The following is a description of a gene set: Human Gene Set: HP_ABNORMAL_HEART_MORPHOLOGY Any structural anomaly of the heart. studied in species Homo sapiens Abnormal heart morphology, and this is the list of marker genes: KAT6B, PORCN, SLC6A6, KIF7, AMMECR1, VPS13B, FBN2, BBS7, MYOT, SLC32A1, PEX14, FRAS1, COL1A1, SEC63, ALG1, SLC22A5, RAB34, FRA10AC1, STAT2, LAMA3, BUB1, CEP19, GALE, NEK10, NFS1, GPC3 (glypican 3), FAM149B1, CEP295, TGIF1, MCM10, TRIP4, CDC42, SMG9, SIN3A, PKD2, ODAD3, GATA6, EBP, NEUROD2, ITK, NUP155, EFEMP2, GATA3, SLC31A1, CXCR4, MNS1, CALCRL, FKRP, HGD, ERCC3, MT-TS2, PRDM13, TTC7A, MT-TW, RAD51C, CPT1A, QRSL1, SRCAP, HAND2, NDUFB10, LAMA2, GNB5, EFL1, FANCD2, IL17RA, TAF2, PLCH1, TMEM67, MYH11, SLC19A2, CEP290, WASHC5, TASP1, MBTPS2, CAV1, VHL, BBS12, BCS1L, MEOX1, ERCC6, TALDO1, GNB2, ACTN2, YARS1, EPCAM, CISD2, BRAF, PPCS, DNAH1, LAMB2, MAX, MYOZ2, PRKG1, FASTKD2 (NCBI Gene Id 22868), ALG8, PSMB9, SOS1, MFAP5, BUB3, KMT2A, RNF113A, SLC34A2, FOXE3, CLPB, GPX4, RPS26, AXIN1, MIB1, IQSEC2, TRAF7, CAPN15, SGCA (NCBI Gene Id 6442), ERAP1, CCDC32 (NCBI Gene Id 90416), AGK, NAGA, GLI2, SETD5, ACVR2B, UBE3B, PIGL, PPM1D, ACSL4, MT-ND6, PGAP1, TMEM218, ADAMTS19, DNAJB4, TAB2, MPDZ, FMN2, SP110, CTBP1, ADK, SYNE2, ZNF423, SPEF2, JAG2, FLI1, PARS2 (NCBI Gene Id 91517), MT-CO2, PRKACA, MAP3K20, BICC1, PEX26, CHD4, CCNQ, MYMK, FGF13, NUP107, HEY2, FOXC2, TRMT10C, BRIP1, RNF135, GLB1, GTF2E2, FTO, PIGV, COL5A2, BBS9, AARS2, IL10, RLIM, COL2A1, GLI1, DYNC2I1, LETM1, ADNP, MID1, RPL27, MT-CYB, MMP2, DZIP1, RAF1, SYT2, LYN, SHANK3, ARF1, HPS1, PIBF1, AHI1 (NCBI Gene Id 54806), FANCG, TRIO, POLA1, PEX2, POLG2, IFIH1, KAT6A, CFAP45, LACC1, AKT3, TUBG1, ZMPSTE24 (zinc metallopeptidase STE24), HNRNPA1, ADCY5, MT-TL1, NDUFS8, HBA2, ODAD4, ATP6V0A2, SMAD2, SPRED1 (sprouty related EVH1 domain containing 1), SGSH, BMP2, MYH3, DNMT3A, DSG2, PIGA, BCOR, MAD2L2, WBP11, B3GLCT, GLI3, RPS20, GJA5, FBXO11, RBPJ, ATP5F1A, CACNA1C, GPR101, TBL2, CBL (NCBI Gene Id 867), SEMA3E, SEMA4A, PGAP2, DTNA, TNNT1, SLC25A20, POMT2, WBP4, POLE, MYL3 (NCBI Gene Id 4634), CXCR2, MYCN, TBX1, MMAB, CC2D2A, LOX (lysyl oxidase), COA6, EXT2, CFAP298, NCAPG2, UFD1, MGME1, TIMMDC1, HLA-DRB1, PLN, OTUD5, MTTP, RPL15, NDUFS4, CFAP221, RAB3GAP2, CIROP, BMPR2, PTPN22, PEX10, WAC, NUP188, SEC24C, SOS2, JUP, NDE1, PRKCZ, FANCM, RPL9, ARL6, CEP41, LTBP3, SMC3, DSE, DSP, SLC4A1, ARVCF, CAP2, SCN5A, MYPN, NADSYN1, CENPE, TLR4, CTNNA3, METTL5, SIK1, TCTN3, SMARCA4, SLC25A24, INTU (NCBI Gene Id 27152), GATA4, ABCC8, PIK3CA, MT-ND2, DVL3, TNNT2, RNASEH1, SH2B1 (NCBI Gene Id 25970), KDM5B, OPA1, FANCL, PDE11A, ACTG2, CALM2, TAFAZZIN, ROBO1, CARS1, MRPL44, RBM8A, LIMS2, TARS1, ITPR1, FANCB, CASQ2, CFAP53, SLC30A10, SPTBN1, RIPK4, DNAJB13, PCGF2, ATP5F1E, NEDD4L, MYO18B, LAMP2, CHEK2 (NCBI Gene Id 11200), LIMK1, MGP, SALL1, CHMP1A, DDX3X, LTBP2, SLC12A2, MYOCD (NCBI Gene Id 93649), CASZ1, YARS2, ODAD2, TRMT5, SQSTM1, SETBP1, MACF1, ALDH18A1 (aldehyde dehydrogenase 18 family member A1), EIF2AK4, TTN, GCSH, SLC35A2, TERT, COA8, NOTCH3, TMEM147, PPFIBP1, NOTCH1, KCNA1, ADAMTS15, ABCA1, GATC, P4HA2, STIL, WDR35, ARMC9, PPP1R13L, VWF, OFD1 (NCBI Gene Id 8481), INS, PACS1, BCR (NCBI Gene Id 729775), MC2R, SHOC2, SEC31A, LRP5, SACS, PCSK9, ATM, PI4KA, YY1AP1 (YY1 associated protein 1), SH3PXD2B, TXNL4A, MASP1, STX5, LEMD2, LRP2, PAX3, COQ4, FNIP1, IRF6 (NCBI Gene Id 7452), MYL2, STAT1, CPLANE1, HBA1, CPLX1, TGDS, KMT2D, ANO5, DNAAF11, NSUN2, USP9X, LDB3, TMEM53, VAC14, NECTIN1, PIK3R2, ATP1A2, UBR1, SALL4, CHD7, CALM1, GTF2H5, CFC1, CSNK2A1, G6PC3, TRAPPC11, SMC1A, UBE2T, SKIC3, FGFR1, NKX2-1, BANF1, TSR2, KIAA0753, KATNIP, FH, WDR26, EIF4A2, TSFM, BCAS3, PQBP1, GALNS, CTLA4, NDUFA10, ADSS1, CCNO, PYGM, IFT122 (intraflagellar transport 122), B2M, RPS28, TNNC1, TCTN1, RECQL4, SIX6, SCO1, KANSL1, LARP7, CITED2, DNAAF5, KCTD1, SPECC1L, NME5, PTPN6, TNXB, KAT5, VPS35L, PAK2, SDHD, PLVAP, AFF4, FAH, DVL1, SUPT16H, TBX20, SLF2, NDUFS6, CYP2R1, TSC1, PEX19, IL17RC, ATP6V1B2, UCP2, TGFBR1, COX16, LIAS, EHMT1, PIEZO2, HSD17B10, CDC45, YY1, PIGF, FOCAD, PHGDH, PNPLA2, TRIM37, D2HGDH (NCBI Gene Id 728294), PEX13, GJA8, TGFB1, ERCC4 (NCBI Gene Id 7509), RPS19, NDUFB9, TPI1, INSR, CBS, RASA2, NDUFAF3, BAG3, IFT172, DNAH5, GATB, GNAO1, SAA1, FLCN, MICOS13, HCN4, IDUA, PCCB, ELN, FANCI, SMARCB1, PHYH, FTCD, ATP13A3, TIA1, VEZF1 (NCBI Gene Id 7716), GBA1 (glucosylceramidase beta 1), CNBP, PYGL, GNAI2 (G protein subunit alpha i2), LRRC56, ODAD1, CHRND, NDUFB3, NFE2L2, PRIM1, DDX6, BAZ1B, GAS1, DEPDC5, LONP1, SETD1A, SLC2A10, INPP5E, BRF1, SCYL2, EPB42 (NCBI Gene Id 2038), IRF4, LMBRD1, SMPD1, TOGARAM1, CCDC174, PTF1A, UBE2A, VPS13A, PMS1, FOXRED1, TAOK1 (NCBI Gene Id 80214), CRLS1, SF3B4, IFNGR1, MT-TC, AFG2A, MRAS, POGZ, BRWD1, IL12B, KLHL41, CLCN3, HNRNPR, OCLN, CHKB, ALG9, KIF15, PKP2, MAP2K1, RYR2, DYSF, ACTA1, GDF1, SLC25A12, PEX1, H4C3, PPP1R21, COX15, DLK1, FOXF1, MYZAP, TAF1A, COX10, NOD2 (NCBI Gene Id 8135), EFTUD2, ZFX, MOGS, LMOD1, PEX5, CACNA1A, SPRED2, NAE1, HLA-B, GBE1, FGF8, MED12, KCNE5, TMEM231, DNAAF1, TRAIP, DMXL2, COX14, GJA1, NDUFB7, CWC27, EIF4H, SBDS, NEK1 (NCBI Gene Id 51037), IFT27, IRAK1, PSMB8 (NCBI Gene Id 5696), AGR2, SERPINE1, CLCNKB, KCNJ11, DISP1, DNAJB11, COX6B1, GRM7, ADA2, PRDM5, TK2 (NCBI Gene Id 7084), CHST14, RBM20, PPP2CA, PDX1, MEGF8, PRDM16, FXN, TLL1, BIN1, PDE6D, CCDC39, IL17F, SNRPN, BBS4, NCF1, DNASE1L3, IFT81, NONO, WNT4, SHMT2, SPAG1, MPL, CRIPTO, DNAJC21, RAD21, ZNF341, GRIN1, TBX2, TMEM216 (transmembrane protein 216), TBCK, SLC1A3, CEP104, MMP23B, MSH6, ERGIC1, SNIP1, MAP2K2, MT-ND4, POLG, APC2, DNAJC19, MED11 (mediator complex subunit 11), GYG1, RNU7-1, NF1, SGCD, ERI1, NDUFAF1, DNAAF6, MIF, MLX, GCK, SMARCC2, NDUFB11, BBS10, ERBB3, HEXB, IFNG (interferon gamma), RYR1, SOX11, RFC2, MPLKIP, MYH7, APOA1, DNAJC30, NIPBL, IPO8, MEG3, IL12A-AS1 (NCBI Gene Id 101928376), ASCC1, PEX16, IGBP1, PRG4, RPS15A, DNA2 (NCBI Gene Id 1763), UBR7 (NCBI Gene Id 55148), BBS5 (Bardet-Biedl syndrome 5), CCDC22, TRIP13, GAA, DOCK11, GTF2IRD1, PHKG2, CRYAB, BRCA1, MRPS14, OTX2, SLC12A3, CORIN, SAT1, DSG1, PTPN11, RNF220, ACTB, SREBF1, HRAS, TMEM107, ACTA2, DNAAF2, EVC2, KDM1A, ABCG8, PEX6, RTTN, EIF2AK3, DPM3 (dolichyl-phosphate mannosyltransferase subunit 3, regulatory), SLC25A22, POLR1A, ZNF687, CHST3, RAP1B, FLII (NCBI Gene Id 2314), SMPX, VARS2, LAMA5, RPS27, COLQ, USP18, ARFGEF2, C4A, KDR, ACAD9, MEN1, ITGA7, COG7, CCND2, TBX4, CFAP52, FOXJ1, PSMD12, NNT, NEK9, MTFMT, PMS2, RPS24, DDX11, FANCF, ALPK3, MAPK1, MT-TV, COQ9, SUCLG1, GMPPB, RMND1, IFT74, EGFR, MT-TN, TPM3, TET3, XYLT1, ACADS, APOB, MAPKAPK5, ADAMTS17, NDUFS3, HOXA13, DNASE1, ZFPM2, STK4, ARL3, MSH2, ZMYM3, MAGEL2, SLC25A4, MT-ND5, PIGO, FRMD5, DLG5, RSPRY1, KCNQ1OT1, DPH5, CKAP2L, AHDC1, TAPT1, KCNJ5, MLXIPL, TXNRD2, MCTP2, NDUFS2, NIPA1, SF3B2, SLX4, TNFRSF1A (TNF receptor superfamily member 1A), SATB1, NDUFA1, UFC1, ADAT3, ABHD5, CPT2, SLC17A5, BAP1, HYDIN, KCNJ2, DGCR2, CSGALNACT1, CLCN7, FCGR2A, CSRP3, KLRC4, VPS37D, ARSL, FGFR2, CUX1, TCOF1, HSPA9, DOCK6, NDUFAF5, FBXW11 (NCBI Gene Id 23291), ACADVL, NAGLU, ESAM, PLEC (plectin), LTBP4, TRDN, PTEN, FOXC1, ZNF469, ZIC3 (NCBI Gene Id 7547), TIAM1, MMP14, RBCK1, RPS6KA3, RPL35A, LZTR1, TTC12, ADAMTS3, PLAGL1, MTX2, STAT4, VPS33B, KCNQ1, KAT8, MT-ND3, TWNK, MT-TK, ATP5F1D, ABCD4, NDUFV2, MT-ND1, SOX6, LIG4, ADAM17, CHD3, ZDHHC9, TRNT1, SCAPER, ENPP1, COL11A1, PCCA, XK, CAMK2A, NDUFAF8, RMRP, KATNB1, HLA-DPA1, FGFRL1, PSMC1, ACTC1, PSEN2 (presenilin 2), PTCH1 (patched 1), GPC6, PIGS, TULP3, PIGP, MT-ATP6, TGFB3, NDUFA6, MYSM1, XRCC2, PDHA1, EPG5, ARID1B, BAG5 (NCBI Gene Id 9529), FREM1, CRKL, MT-TH, POLR3A, HGSNAT, LMOD2, DES, ALMS1, PCNT, HNRNPH2 (heterogeneous nuclear ribonucleoprotein H2), PKDCC, PDGFRA, TMEM126B, CHUK, RFWD3, MYH8, CEP120, ADAMTS10, ATP6V1E1, JMJD1C, FILIP1, ANAPC7, DACT1, MTO1, HACD1, NXN, PPARG, PRKACB, AUTS2, AEBP1, DPH2, PIGT, RRAS2, FANCA, EOGT, RAB23, SLC38A3 (NCBI Gene Id 10991), CLIC2, SELENON, RNU4-2, KIF11, FBLN5, ABCA3, FCGR2B, RPL8, MMACHC, COL25A1, POLD1, GNPTAB, ERCC1, ROBO4, RPL3L (NCBI Gene Id 6123), MT-ATP8, ASXL1, KLHL24, GUSB, DCAF8, MED13L, PKD1, CCBE1, HNRNPA2B1, HDAC8, PRR12, VCP, NAXD, RSPH1, ERMARD (ER membrane associated RNA degradation), NPHP1, KBTBD13, MMP1, CDC42BPB, MKS1, STRA6, BBS1, TAF6, BMPR1A, KCNJ8, NSDHL, ALX3, NEXN, MIR17HG, DGCR6, DNAI2, TMTC3, BBIP1, PRKAR1A, BMP6, LSM11, CDH2, SDCCAG8, STK36, PGM1, MMUT, KIF3B, LMNA, FLNA, HAAO (3-hydroxyanthranilate 3,4-dioxygenase), FDFT1, HBB, JPH2, STX1A, DST, NOTCH2, HCCS, TNNI3, MCIDAS, RRM2B, ATRX, DHCR7, PACS2, NDUFA2, SPEN, GTF2IRD2, SCO2, COL5A1 (NCBI Gene Id 1289), ARSK, CD96, RERE, TGFB2, GLA, CLEC7A, UMPS, TXNDC15 (thioredoxin domain containing 15), ANK1, GRB10, METTL27, ROR2, WT1, SCN1B, SATB2, UQCRC2, BRD4, RPL11, ATAD3A (ATPase family AAA domain containing 3A), ZNF668, RNASEH2C, MLYCD, JAG1, MED25, ATN1, SKIC2, TFAP2B, THOC6, ERCC2, PRKCSH, DAW1, LRP12, IFT140, CCDC65, RPL35 (ribosomal protein L35), SMN1, CASK, GNE, STAG1, SLC40A1, FHL1, GP1BB, SNRPB, RPL10, ADAR, NKX2-6, RPS29, PUF60, SUFU, STAT3, ABCG5, SLC25A3, BBS2, COL1A2, RPL26, TBC1D24, SDHB, TNFRSF11A, TWIST1, DNAH11, SYT1, RPGRIP1, TTPA, ALDH1A2, FUCA1, SMARCE1, FLAD1, MGAT2, PRUNE1, ARX, TREX1, RPGR, MICU1, HLA-DPB1, LDLRAP1, NIPA2, NAA20, NDUFS7, ARL13B, STRADA, PURA, TBX3, TMEM94, CYP27A1, DDX59, IL12A, BMP4, PTCH2, SYNE1, MIPEP, ABCC6, PPA2, PNKP, TMEM270, EPHB4, CRELD1, RSPH9, ARID2, ZNF462, ANKRD1, PBX1, SLC29A3, ESS2, LRPPRC, RIGI, ELAC2, RSPH3, LARS2, LCK, GNS, PLOD1, B3GAT3, SOX4, PPP2R5D, EXTL3, JAM3, WNT3, TPM1, ATP1A3, NDUFA11, SHH, MYBPC3, XYLT2, CLXN, ALG12, BRCA2, GSN, GPC4, NRAS, COX7B, DCPS, PLD1, PTPN14, HAMP, POMK, LBR, SCLT1, DYRK1A, CCDC28B, IDH2, ALG3, MAP1B, FLT4, SNX10, MYH6, MRPS22, HEATR3, VIPAS39, TBX5, SRY, IGF1R, CACNA1D, SURF1, NBAS, ARSB, SPOP, BTK, ABCC9, LAMB3, GTPBP3, SNUPN, SMAD3, TMEM126A, ESCO2, NSMCE2, ASXL2 (NCBI Gene Id 55252), SVIL, AARS1, FBN1, MED23, CUL3, AHCY, PIGG, UBE4B, SPP1, CANT1, PPP1CB, PHKA2, TRIM32, FIG4, RRAGD, ATP6AP2, RNASEH2A, DMPK, NKX2-5, HJV, SMAD6, AMER1, HES7, TP63, NPHP3, WDPCP, HADHA, HIBCH, NELFA, AGGF1, LUZP1, WLS, FAT4, CAV3, SMARCD1, ARHGAP31, DNAH9, MYLK2, MKKS, TPK1, NODAL, RSPH4A, ERCC8, KMT2C, HMGCL, MT-TQ, GYS1, FHOD3, CDK13, NEB, LYST, BOLA3, SIAH1, ABL1, KYNU, TRIM8, FANCC, KLF1, CCND1, ACAD8, TCTN2, SPEG, TFR2, EYA4, SPTB, NDUFV1, CDKN1C, GATAD1, CCDC40, DGCR8, NFIX (nuclear factor I X), CACNA1S (calcium voltage-gated channel subunit alpha1 S), TGFBR2, DRC1, CLIP2, POMGNT1, LMNB1 (lamin B1), SLC37A4, SLC25A36, CALM3, MAT2A, SDHA, FMR1, ARID1A, PDPN, PMM2, TOPORS, DPYSL5, DNAAF3, GANAB, MMP21, SRP54, DBR1, SFTPB, NDUFAF2, DNAAF4, STAR, AGO2, POMT1, KIF20A, CLN3, B3GALT6, DLL1, THPO, NUBPL, CCDC103, WFS1, TNFSF11, IGF2, DPH1, INVS, ECHS1, RPL18, CSPP1, KDM3B, EXOC2, INTS1, SOX2, VCL, MYRF, SGCG, COG6, NPPA (natriuretic peptide A), SDHAF1, DNAI1, CHRNG, PEX11B, ITPA, PSEN1, HSD11B2, PALB2, DLD, EBF3, UBE3C, RELN, OTUD6B, RNU4ATAC, H3-3B, CDON, TRRAP, TPM2 (NCBI Gene Id 7169), RARB, PIEZO1, LAMA4, ATP5MK, MRPL3, NPR3, PEX3, CHRNA1, TKT, ZMYND10, NAA10, PRKD1, TRAF3IP2, ATIC, TKFC, ANKS6, TNNI3K, PRKAG2, RFX7, CDK10, PRTN3, SKI, DNAL4, RPGRIP1L, FOS, IFT56, DSC2, CYP27B1, SIX3, FAS (NCBI Gene Id 355), ADORA2A, SGO1, BUB1B, UPF3B, TCIRG1, ZNF699, DNAL1, NDUFAF4, STAMBP, TPR, NKAP, IDS, COA5, RPL5, TMEM260, ANKRD11, ECE1, SCN2A, DOHH, XRCC4, CREBBP, NHLRC2, FHL2, LAMC2, LEMD3, SMAD4, NSD1, BRCC3, RPS7, ACADM, PIGQ, TMEM43, CFAP300, STAG2, SNX14, POR, PRRX1, MLH1, FLNC, RPS10, AGPAT2, RBM10, H4C9, DHX9, MUTYH, FOXP2, C2CD3, SAMHD1, B9D2, CDKL5, IL23R, PEX7, DCHS1, GAS2L2, HNRNPU, SLC5A6, EP300, MAF, RPL31, LDLR, HDAC4 (NCBI Gene Id 9759), MT-CO3, TMEM70, RTL1, CBY1, WDR37, TANGO2, HADH, RREB1, PKD1L1, THSD1, CAPNS1, FOXP1, BSCL2, DEAF1, MT-TT, SMG8, TSC2, WARS2, GABRD, COMT, HNRNPK, SIK3, FIBP, MEIS2, ZIC2, KRAS, NDUFC2, ARL2BP, B9D1, CTU2, FKBP6 (FKBP prolyl isomerase family member 6 (inactive), NCBI Gene Id 8468), BGN (biglycan), CAVIN1, FLNB, CHRM3, CTCF, CEP57, KIFBP, CFAP418, RNASEH2B, GLRX5, COX5A, CDK8, IDH1, MSX1, AGL, MT-TF, FANCE, KIAA0586, BICRA, COQ2, ZEB2, COL3A1, RAD51, CPE, COG1, LZTFL1, ZBTB7A, EMD, ZMYM2, RRAS, TMEM237, BUD23, RASA1, SPTA1, SCUBE3, HSPG2, MRPL39, PAH, RRAGC, GET3, OGT, SLC7A7, NEU1, HADHB, NR2F2, AIP, HYLS1, ATP2B1, TOP3A, UBAC2, TBX22, ALKBH8, HOXD13, ZFP57, GATA1, RPS17, RAI1, NSD2, SZT2, ATPAF2, SGCB, FADD, DYNC2LI1, GNPAT, ARCN1, SON, HFE, FUT8, THSD4, TMCO1, VPS33A, CCDC47, ESPN, DMD, KCNH1, RAC1, CDH23, TTR, QRICH1, MT-CO1, COL18A1, PEX12, DPF2, ALX1, FZR1, EDNRA, C1QBP, IRX5, DOLK, H3-3A, GATA5, HYMAI, SVBP, RSPO2, LTBP1, CCR1, PAM16, ATP6V1A, FGFR3, TTC8, SCAF4, DLL4, IKZF1, RIT1, UQCRFS1, TCAP, GTF2I (NCBI Gene Id 90875), CFAP74, NDUFS1 (NCBI Gene Id 55372), CFTR, KDM5A, GDF6, HIRA, FKTN, EVC, ATP9A, IL6, MEFV, PLXND1, COQ7, TMPO, ALG5 (ALG5 dolichyl-phosphate beta-glucosyltransferase), FOXH1, NEK8 (NCBI Gene Id 284086), MAP3K7, GDF3, KCNAB2, BLTP1, MRAP, NME8, MYLK, COL7A1, SOX9, PIGN, DEF6, SARDH, KDM6A, THBS2 (thrombospondin 2), CRB2, FBXL4